Given this list of marker genes Cd79b (CD79B antigen), Gpr65, Pxk, Cd83, Cnr2, Mcl1, Ms4a1, Wipf1, Btg1, Snapin, Cxcr5, Gga2, Capg, Cd22 (NCBI Gene Id 269895), Rgs14, Rasa3, Ctss, H2-Aa, Adcy7, Il10ra, Rgl2, Slc25a53, H2-DMb1, Il4i1, Ctsh, Hip1r, Serpinb1a, Igkv14-111, Sema4d, Lat2, Aldh2, Ltb, H2-DMa, Uba7, Birc3, Soat1, Scd1, Samhd1, Pip4k2a (NCBI Gene Id 99429), Capn1, Ly86, Itgav, Crybg1, Cd74, Ptprc (NCBI Gene Id 19264), Lcp1, Ptpn6, Vcam1, Gmip, Sipa1, Dock2, Gns, Macf1, Il4ra, Irf8, Il2rg, Neat1, Lpp, Dtx1, Ripor2, here is a description of the gene set: The Emu-myc transgenic mouse has provided a valuable model for the study of B-cell lymphoma. Making use of gene expression analysis and, in particular, expression signatures of cell signaling pathway activation, we now show that several forms of B lymphoma can be identified in the Emu-myc mice associated with time of tumor onset. Furthermore, one form of Emu-myc tumor with pre-B character is shown to resemble human Burkitt lymphoma, whereas others exhibit more differentiated B-cell characteristics and show similarity with human diffuse large B-cell lymphoma in the pattern of gene expression, as well as oncogenic pathway activation. Importantly, we show that signatures of oncogenic pathway activity provide further dissection of the spectrum of diffuse large B-cell lymphoma, identifying a subset of patients who have very poor prognosis and could benefit from more aggressive or novel therapeutic strategies. Taken together, these studies provide insight into the complexity of the oncogenic process and a novel strategy for dissecting the heterogeneity of B lymphoma. Down-regulated genes in the B lymphocyte developmental signature, based on expression profiling of lymphomas from the Emu-myc transgenic mice: the Large Pre-BII stage. from publication Mori S, Rempel RE, Chang JT, Yao G, Lagoo AS, Potti A, Bild A, Nevins JR (PMID 18922927) studied in species Mus musculus Mouse Gene Set: MORI_LARGE_PRE_BII_LYMPHOCYTE_DN